The following is a description of a gene set: Human Gene Set: GOBP_MAINTENANCE_OF_POSTSYNAPTIC_SPECIALIZATION_STRUCTURE studied in species Homo sapiens A process which maintains the organization and the arrangement of proteins in the presynaptic specialization., and this is the list of marker genes: ITGB3, SYNGAP1, CSMD2, PPFIA2, DLG1, OPHN1, SHANK1, ARF6, PRICKLE1, GIT1, RAPSN